The following is a description of a gene set: species: Homo sapiens from publication Chen Y, Wang X (PMID 31504780) Human Gene Set: MIR1295B_3P Genes predicted to be targets of miRBase v22 microRNA hsa-miR-1295b-3p in miRDB v6.0 with MirTarget v4 prediction scores > 80 (high confidence targets)., and this is the list of marker genes: SOS2, RBM24, SMIM17, SAMD4B, HYDIN, SLC41A2, GASK1A, SLC17A5, SH3GL3, PRMT3, TMEM41A, DOCK9, ABCC5, C5orf63, CHM, ADAMDEC1, FRMD3, GDAP2, KLRF1, TRAF6, FAM20A